Given this list of marker genes Ifng, Nupr1, Map2k1, Hsd11b1, Rptor, Prkag2, Cbfa2t3, Ncor1, Trp53, Gck, Slc4a4, Cda, Flcn, Prkn, Tmsb4x, Vcp, Prkaa2, Slc4a1, Trex1, Htr2a, Myc, Slc2a6, Hif1a (NCBI Gene Id 15251), Mlxipl, Jmjd8, Prkag1, Me2, Adcy10, Il4, Esrrb, Bend3, Hdac4, Gpd1, Psen1, Guca1b, Arl2, Il3 (NCBI Gene Id 16187), Zbtb20, Atpsckmt, Gpi1, Gapdhs, Prkaca, Ier3, App, Eno1, Ndufc2, Mtor, Myog, Ppargc1a, Mlx, Arnt, Rd3, Ppara, Actn3, Fbp1, Pfkfb1, Prkag3, Kat2b, Mtch2, Igf1, Dnm1l (NCBI Gene Id 74006), Ins1, Lacc1, P2rx7, Antkmt, Git1, Pid1, Sik2, Mlst8, Macroh2a1, Zbtb7a, Eif6, Hnf1a, Tigar, Insr (NCBI Gene Id 319666), Bcl2l1, Guca1a, Trim63, Aldob, Parp1, Ppp2ca, Ogt, Ddit4, Prkaa1, Ins2 (insulin II), Src, Ep300, Nos3, Sirt6, Slc25a12, Fis1, Dnajc30, Tspo, Sphk2, Entpd1, Prxl2c, Me1, Uchl1, Adora2b, Stat3, Atp5if1, Eno1b, Trem2, here is a description of the gene set: Mouse Gene Set: GOBP_REGULATION_OF_NUCLEOTIDE_METABOLIC_PROCESS species: Mus musculus Any process that modulates the frequency, rate or extent of the chemical reactions and pathways involving nucleotides.